Given this list of marker genes INHBA (inhibin subunit beta A), MUCL1, IL23A, CCNA1, DUSP5, CTSL (NCBI Gene Id 1514), CXCL8, ATP2B1-AS1, LINC00299 (long intergenic non-protein coding RNA 299), OTUD4, TNFSF15 (NCBI Gene Id 9966), MIR3945HG, CXCL3, KDM7A-DT, SLC7A5, PLAUR, ZC3HC1, PHLDA2, NSMAF, IL36RN, USP53, SPAG5, SYNPO2, LINC00847, ZMIZ1-AS1, F8, SGMS2, PPARG, UBTD2, NEU1, ST3GAL6, CCRL2, DUSP2, GARS1, CHAC1, CREB5 (cAMP responsive element binding protein 5), GCLM, LINC-PINT, RRAD, TBC1D7, MAP3K8, PLPP3, IER3, DOLK, STX4, RHEB, IL18, LDLRAD4, NPC1, F3, PTGER1, SCML1, SNX9, GPRC5A, TXNRD1, NLRP3, EGR1, IL1A, PRXL2C, RAPGEF2, ADTRP, ACOD1, BANP, PTP4A1, DYRK3, SLC9B2, EGLN3, TXN, CYB5D1, PMAIP1, ENSG00000215022, STARD8, GCNA, CKS2, GLA, USP12 (ubiquitin specific peptidase 12), INSIG1, DENND4A, STARD4, CFLAR, MIR3142HG, ST18, OSGIN2, SRXN1, RASGEF1B, FBXO30, ATP2B1, ABL2, P2RY1, PLD1 (phospholipase D1), FNIP2, TP53BP2, CD274, S1PR3 (sphingosine-1-phosphate receptor 3), SLC38A2, ARL5B, PLK3, CCR7, NFKBIZ, SLC3A2, C11orf96, ADM, TAF9, SNUPN, DCSTAMP, SPRY2, ZSCAN5A, P2RX4, MGAM, ACSL3, ZNF674-AS1, ASPH, CFLAR-AS1, ADORA2A-AS1, MFSD2A, RIT1, AQP9, IL10, SAV1, MMP1, NMRAL2P, PTGS2, TSLP, CXCL1, NIPAL4, DTL, FERMT2, ADRB2, SFMBT2, GEM, MIR155HG, CCL18, SELENOK, MMP10, RGCC, NEDD4L, PDSS1 (decaprenyl diphosphate synthase subunit 1), CSF1, SPINK1, IL36G, JUN, CSTB, ZC3H12A, CCL20, CXCL2, NOCT, PIM3, EID3, SPP1, CDK1, TUBE1, UPP1, ETS2, DYNLT2B, TNF, RYBP, SIAH2, ID2, IL1B, HOMER1, DDIT4, KLHL21, ASNS, SLCO4A1, MAGI2-AS3, HECW2, EIF2AK3, YRDC, FOSL1, MMP19, GADD45A, MSANTD3, DLGAP1-AS2, E2F7, PLEK, SESN2, LYSET, SPAG9, MOAP1, DNAJB4, TNIP3, PPP1R15B, SNAPC1, UBE2J1, DUSP1, ENSG00000284634, MAPK6, TEX14, PLCXD1, GNPDA1, SFR1, SGPP2, LRRC8B, CSRNP1, ANKRD28, here is a description of the gene set: Genes up-regulated in comparison of monocytes treated with anti-TREM1 and 5000 ng/ml LPS (TLR4 agonist) versus untreated monocytes. studied in species Homo sapiens from publication Dower K, Ellis DK, Saraf K, Jelinsky SA, Lin LL (PMID 18292579) TREM-1 is an orphan immunoreceptor expressed on monocytes, macrophages, and neutrophils. TREM-1 associates with and signals via the adapter protein DAP12/TYROBP, which contains an immunoreceptor tyrosine-based activation motif (ITAM). TREM-1 activation by receptor cross-linking is pro-inflammatory, and can amplify cellular responses to Toll-like receptor (TLR) ligands such as bacterial lipopolysaccharide (LPS). To investigate the cellular consequences of TREM-1 activation, we have characterized global gene expression changes in human monocytes in response to TREM-1 cross-linking in comparison to and combined with LPS. Both TREM-1 activation and LPS up-regulate chemokines, cytokines, matrix metalloproteases, and PTGS/COX2, consistent with a core inflammatory response. However, other immunomodulatory factors are selectively induced, including SPP1 and CSF1 (i.e., M-CSF) by TREM-1 activation and IL-23 and CSF3 (i.e., G-CSF) by LPS. Additionally, cross-talk between TREM-1 activation and LPS occurs on multiple levels. While synergy in GM-CSF protein production is reflected in commensurate mRNA abundance, comparable synergy in IL-1b protein production is not. TREM-1 activation also attenuates the induction of some LPS target genes, including those that encode IL-12 cytokine family subunits. Whereas positive TREM-1 outputs are abolished by the PI3K inhibitor wortmannin, this attenuation is largely PI3K-independent. These experiments provide a detailed analysis of the cellular consequences of TREM-1 activation, and highlight some of the complexity in signal integration between ITAM- and TLR-mediated signaling. Human Gene Set: GSE9988_ANTI_TREM1_AND_LPS_VS_VEHICLE_TREATED_MONOCYTES_UP